The following is a description of a gene set: Human regulatory T cells (TR) cells have potential for the treatment of immune mediated diseases, such as graft versus host disease, but the anergic phenotype of these cells makes them difficult to expand in vitro. We have examined the requirements for growth and cytokine expression from highly purified human TR cells, and correlated these findings with the signal transduction events of these cells. We demonstrate that these cells do not proliferate or secrete IL-10 even in the presence of high doses of IL-2. Stimulation with a superagonistic anti-CD28 antibody (clone 9D4) and IL-2 partially reversed the proliferative defect, and this correlated with reversal of the defective calcium mobilization in these cells. Dendritic cells were effective at promoting TR cell proliferation, and under these conditions the proliferative capacity of TR cells was comparable to conventional CD4 lymphocytes. Blocking TGF-beta activity abrogated IL-10 expression from these cells, while addition of TGF-beta resulted in IL-10 production. These data demonstrate the ability of dendritic cells to provide proper costimulation to overcome the anergic phenotype of TR cells. In addition, these data demonstrate for the first time that TGF-beta is critical to enable TR cells to express IL-10. from publication Bonacci B, Edwards B, Jia S, Williams CB, Hessner MJ, Gauld SB, Verbsky JW (PMID 22562448) Human Gene Set: GSE22045_TREG_VS_TCONV_UP species: Homo sapiens Genes up-regulated in comparison of regulatory T cell (Treg) versus conventional T cells., and this is the list of marker genes: GRID1-AS1, RGN, PCTP, HYCC2, FHIP2A, HFE, MAML1, TSACC, IGHMBP2, CEP55, STX1A, GMNN, GABRR3, TPX2, GPR19, SLC4A3, SMC6 (NCBI Gene Id 79677), ZC2HC1A, N4BP1 (NCBI Gene Id 9683), GYPB, CYP1A2, TNFSF10, SAG, DGCR5, CASK, CD86, KRT7, PARD6G (NCBI Gene Id 84552), TRIM14, CDT1, CDC42EP4, CENPU, ADAMTS18 (NCBI Gene Id 170692), CTIF, ADGRD1, CIDEC, MUC13, ABHD11, ZW10, CMTM3, HEATR3, PRELP, CMYA5, CCNG2, CHEK1, OXT, SCLT1, SHMT2, NCAPG2, SSTR3, RDH10, CFAP65, KIF15 (kinesin family member 15), VAX2, SLC38A5, MAN1A2, TSPOAP1, SEC24A, PPP1R12C, HTATSF1P2, DEFB125, ST8SIA6-AS1, HTATIP2, RBM42, LINC01095, KRTAP3-1, CD1B, VASH1, POMT2, TMEM247, PDE4A, PKHD1L1, HIP1, RNF187, ATAD2, HSPA8, ACOT9, ME1, DENND1B, RGMB-AS1, CAMTA2, SEL1L3, PSMA6, DAAM1, CD58, TBCB, CYP26A1, FOXP3 (forkhead box P3), RAC2, CASP8, PHC2, ZNF280C, TNIP3, PPP2R2B, RUBCN, MTMR7, MIAT, NTRK3, KIF11, NEK2, PBK, FAM186A, F2R, CENPE, SLC22A13, ZRSR2P1, CHST7, CXCR3, SPRN, ANXA2P2, MYO1G, PCDH10, ABCG2, STX6, H4C8, NAGA, MAF, HMGA2, TTC38, RNF181, PTP4A1, CDKN3 (NCBI Gene Id 1033), IL10RB-DT, BAIAP2L1, METRNL, SAP30, VXN, CDO1, DNAJC15, PKN3, CD83, KLK4, LARGE-AS1, IQGAP2, COL13A1, LHX9, CDC42EP3, ABHD2, LINC02743, LINC00307, LCT, ASB6, RALGPS1, PIN4 (NCBI Gene Id 5303), CLEC4F, LILRB1, CDC42BPB, CORO1B, KIR3DS1, SDC4, RORA, CASKIN1, IL18R1, OTULIN, MFSD6, TESMIN, CAPS2, COL9A3, CCR6, ACTN4, ZNF804A, C1orf216, ATP8B3, RNF186, ZSWIM8, ALDH9A1, PPIF (NCBI Gene Id 10105), JAG2, SLC5A7, NAV2, CFAP206, SLC35F2, TMEM132A, GLOD5, ADAM33, TOX, HS3ST3B1, SANBR, NABP1, NLN, TNFRSF21, SIPA1L1, GJB6, H2BC4, CARTPT, TTC7A (NCBI Gene Id 57217), UBR1, ISG20